Given this list of marker genes Gm10637, Pyroxd1, Strn3, Dmac1, Maf, Pprc1, Airim, Pemt, Etv1, Timm13, Gm6556, Brpf1, Sharpin, Elk1, Gm12258 (predicted gene 12258), Smarcal1, Mrm1, Smad3, Qtrt2, Dhx35, Mir1956, Creb3, Klc4, Timm23, Pds5a, Zfp386, Kcnab1, Gtpbp2, Gm24259, Krr1, Pdgfrb, Snhg17, Maf1, Dock9, Ccdc146, Scmh1 (NCBI Gene Id 29871), Fut10, Nbas, Akt2, Cdsn, Tle1, Gtf3c6, Atn1, Zpr1, Prmt6, Notch1, Fbxo48, Rnf181, Zfp784, Rnaseh2c, Gart, Mir206, Bnc2, Svbp, Zmpste24, Fyco1, Mrpl2, Zfp106, Stk40, Ccn2, Cab39l, Spag9, Dhx33, Gm14280, Abl2, Cldn12, Gm17455, Rbm25, Gjb4, Calcoco1, Mrpl21, Mtx1, Pelo, Gm12089, Meis2, Crls1 (NCBI Gene Id 75371), Gli3, Arid5b, Tmcc2, Ttc13, Git2, Tmem232, Usp5, Trmt10b, Rrm2, Hoxb9, Rptor, Ncln, Dhcr7, Nudt13, Ubald2, Ighmbp2, Ston1, Unk, Wnk1, Adnp2 (NCBI Gene Id 71470), Rmdn1, Evi5l, Kif1b, Gm12602, H4c16 (NCBI Gene Id 674678), Prss46, Mad1l1 (MAD1 mitotic arrest deficient 1-like 1), Nedd8, Zfp36l1, Enthd1, Rpia, Ssbp1, Fto, Rasa4, Ing3, Dmap1, Invs, Ssbp3, Ccn1, Liph (NCBI Gene Id 28111), Ccp110, Bub1b, Mir92b, Med23, Aprt, Cactin, Nsd3, Eif4e, Fbxw7, Nop14, H3c6, Tspyl1, Sumo3, Luc7l, Ints9, Gsk3a, Khdrbs1, A630023A22Rik, Hmbox1, Gm11335, Prkar2a (protein kinase, cAMP dependent regulatory, type II alpha), Clcf1, Dusp6, Cnot1, Ltbp1, Il1r1, Heatr5b, BC025920, St3gal2, Arhgap22, Adamtsl4, 8430429K09Rik, Ehmt2, Lncpint, Rpl38, Gm5444, Mogat1, Gm5641, Banp, Setmar, Zmym6, Cdk11b, Tmem43, Tceal9, Runx2os2, Echdc3, Znhit3, Phb1, Lgmn, Dbt, Vcam1, Baalc (brain and acute leukemia, cytoplasmic), Zfp84, Dph5, Smurf1, Msh5, Lsm14b, Disp1, Vps53, Cenpu, Gm16508, Tle4, Inava, Esrra, Arv1, Mei4, Bub3, D330050G23Rik, Ap1m1, Trappc3, Pdia4, Prpf4, Pomgnt1, Sertad2, Gm28441, Tdg, Phf12, Ap2m1, Pcm1, Ifrd2, Mettl23 (NCBI Gene Id 76492), Prcc, Tex14, Cuedc1, Gm42745, Abl1, Cnksr3, Nqo2, Dmtf1, Tlcd2, Ets1, Psmb6, Fam185a, Gm15764 (predicted gene 15764), Cd63, Ddx24, Mrps31, Inip (INTS3 and NABP interacting protein), Rbbp6, Parg, Ska2, Ttc14, Kbtbd7, Dcaf12, Arfgap2, Lincmd1, Cdca8, Gm23608, Bahcc1, 1700023H06Rik, 4930513N10Rik, Herpud1, Smim13 (NCBI Gene Id 72908), Zbtb45, 1700008O03Rik, Lhx9, Rtn3, Gm16023, H2ac6, Os9, Zfyve1, Uxs1, Bicdl2 (NCBI Gene Id 212733), Gmpr2 (guanosine monophosphate reductase 2), Rny3, Rab11b, B530045E10Rik, Wincr1 (NCBI Gene Id 768272), Ggps1, Hsph1, Ccdc191, Gpcpd1, Ube2i, Ddx23, Erp44, Tra2a, Ppp6c, 1700039M10Rik, Dtx4, Serpinb6b, Mis18a (NCBI Gene Id 77054), Snrnp27, Col5a1, Pax8, Gm16253, Six4, H4c8, Ccnk, Erh, Nfyc, Ndc1, Poc1a, Fgl2, Gpr149 (NCBI Gene Id 229357), Casq1, Fitm2, Rangap1, Rrm1, Cald1 (NCBI Gene Id 73913), Pknox2, Cenpc1, Sclt1, Otx1, Setd3 (NCBI Gene Id 77715), Clpb, Gpatch11, Spry1, Iftap, Gtpbp1, A930015D03Rik, Fblim1, Ldhb, Tmem115, Grk4, Vbp1, Eps8, Zfp963, D7Ertd443e, Cdc16, Ankmy1, Gm25138, Tsnaxip1, Arid4b, Ccdc163, Bet1, Psmc4, Snora2b, Ccnd3, Rad54l, Col27a1, Pfas, Eldr, Slc39a9, Nav3, Rassf1, Tusc2, Tln1, Alkbh5, Etfb, Eef1akmt1, Tcf7l2, Fam50b, Crtc2, Nnt, Cdc26, Stradb, Kdm8, Nup153, Ccnl1, Zfp938, Zfp322a, Inpp5b, Cdca3 (cell division cycle associated 3), Kdm3a, Tec, Smyd2, Krt80, Ndufs7, Endod1, Patl1, Ccar2, Prr11, Mmachc (methylmalonic aciduria cblC type, with homocystinuria), 9430015G10Rik, Erlin1, Cdk5rap1, Ttc1, Dnaja2, Slc45a4, Gm17501, Rpgrip1l, Chchd4, AU041133, Gzmk, Gm26535, Gm37359, H6pd, Son, Tent2, N4bp2l2, Ankhd1, Ric8b, Rnf185, Gm12415, Stoml2, Meis1, Ranbp10, Dock6 (dedicator of cytokinesis 6), Rdh5, here is a description of the gene set: from publication Yevshin I, Sharipov R, Kolmykov S, Kondrakhin Y, Kolpakov F (PMID 30445619) species: Mus musculus Genes containing one or more binding sites for (Tlx1) in their promoter regions (TSS -1000,+100 bp) as identified by GTRD version 20.06 ChIP-seq harmonization. Mouse Gene Set: TLX1_TARGET_GENES